The following is a description of a gene set: Mouse Gene Set: GOBP_REGULATION_OF_OVARIAN_FOLLICLE_DEVELOPMENT Any process that modulates the frequency, rate or extent of ovarian follicle development. studied in species Mus musculus, and this is the list of marker genes: Hyal3, Ptger4, Amh, Zp3, Mfn2, Gnrh1, Rac1, Src, Umodl1